Given this list of marker genes Phox2b, Ttbk2, Plxna2, Ephb2, Ephb1, here is a description of the gene set: The migration of a cell in the hindbrain in which cells move orthogonal to the direction of radial migration. Mouse Gene Set: GOBP_HINDBRAIN_TANGENTIAL_CELL_MIGRATION studied in species Mus musculus